Given this list of marker genes TBPL1, HERC4, YTHDC2, WDR44, STON1-GTF2A1L (STON1-GTF2A1L readthrough), TREM1, CFD, REEP1, SORBS2, KLHL32, DGKK, MED15, SRD5A2, LYPD5, DUSP3, C4orf19, NTN1, THADA, COLGALT1, SMAP2, ERBB4, WNT9B, COL5A2 (collagen type V alpha 2 chain), HLF, PRPF40A, CEP350 (NCBI Gene Id 9857), PKHD1, ARID3B, CCDC92, PAN3, FREM1, ZBTB20, VPS11, CTDSP1 (NCBI Gene Id 58190), ZNF74, ZFAND2A, AIG1, GCNT4, SP100, ITGB3BP, OSBPL11, NPPA, MZF1, SLC30A5, DEFB129, ZNF526, TENM1, ASPH, RTL4, E2F2, CD47, RCHY1, ASXL2, here is a description of the gene set: Human Gene Set: MIR3907 studied in species Homo sapiens from publication Chen Y, Wang X (PMID 31504780) Genes predicted to be targets of miRBase v22 microRNA hsa-miR-3907 in miRDB v6.0 with MirTarget v4 prediction scores > 80 (high confidence targets).